Given this list of marker genes KCND1, IAPP, B3GNTL1, PML, RANBP6, HAS1, FOXH1 (NCBI Gene Id 8928), ZBTB25, CTRL, CTRC, CMKLR2, IL10, FSHR, PNLIPRP2, MEP1A, ABCB10, PDE5A, ANGEL1, CPA2, SEL1L, PRDM1, GNRH2, EXOC6B, RETREG1, CELP, ABCD1, ARHGEF15, NCR2, BRAP, PNLIPRP1, XPA (NCBI Gene Id 7507), ERCC2, GCG, RUNX2, LEFTY1, ALMS1, STX11, ERC2-IT1, TRAC, SERPINI2, CCL27, PAX2, IFNA6 (interferon alpha 6), EPB41, TCL1B (NCBI Gene Id 9623), CEP152, PRSS3P3, here is a description of the gene set: High-throughput gene expression profiling has become an important tool for investigating transcriptional activity in a variety of biological samples. To date, the vast majority of these experiments have focused on specific biological processes and perturbations. Here, we have generated and analyzed gene expression from a set of samples spanning a broad range of biological conditions. Specifically, we profiled gene expression from 91 human and mouse samples across a diverse array of tissues, organs, and cell lines. Because these samples predominantly come from the normal physiological state in the human and mouse, this dataset represents a preliminary, but substantial, description of the normal mammalian transcriptome. We have used this dataset to illustrate methods of mining these data, and to reveal insights into molecular and physiological gene function, mechanisms of transcriptional regulation, disease etiology, and comparative genomics. Finally, to allow the scientific community to use this resource, we have built a free and publicly accessible website (http://expression.gnf.org) that integrates data visualization and curation of current gene annotations. Genes up-regulated specifically in human pancreas. from publication Su AI, Cooke MP, Ching KA, Hakak Y, Walker JR, Wiltshire T, Orth AP, Vega RG, Sapinoso LM, Moqrich A, Patapoutian A, Hampton GM, Schultz PG, Hogenesch JB (PMID 11904358) Human Gene Set: SU_PANCREAS studied in species Homo sapiens